Given this list of marker genes UPP1, DGUOK, GART, NUDT5, AK9, ENTPD6, GMPR2, RRM1, TXNRD1, GLRX, TYMP, UMPS, ITPA, NT5C1A, DPYD, DCTPP1, CAD, ENTPD4, TXN, UCK1, AGXT2, ENTPD1, PPAT, GUK1, NT5C2, NUDT16, RRM2, DTYMK, ADK, XDH, ADSL, NT5E, ENTPD7, ENTPD5, PUDP, UCK2, NUDT13 (nudix hydrolase 13), AK8, ENTPD3, TK2, UPP2, GSR (glutathione-disulfide reductase), TYMS, TK1 (NCBI Gene Id 7083), NUDT18, AMPD2, IMPDH1, ADA, NUDT9, ADSS1, AK5, ATIC, NME4, APRT, AMPD1, NT5M (NCBI Gene Id 56953), NT5C, GMPR, ENTPD8, PNP, ENTPD2, DCK, NME3, HPRT1, ADSS2, AMPD3, PAICS, NUDT15, DCTD, ADPRM, CTPS1, AK1, SAMHD1, DNPH1, DUT, NUDT1, PFAS, IMPDH2, CTPS2, DPYS, GMPS, AK6, MAPDA, UCKL1, NT5C3A, CMPK1, NT5C1B, NME1, AK7, CDA, DHODH, AK2, NME6, NME2, UPB1, AK4, RRM2B, GDA, here is a description of the gene set: part of: Metabolism species: Homo sapiens Reactome Pathway: Metabolism of nucleotides Nucleotides and their derivatives are used for short-term energy storage (ATP, GTP), for intra- and extra-cellular signaling (cAMP; adenosine), as enzyme cofactors (NAD, FAD), and for the synthesis of DNA and RNA. Most dietary nucleotides are consumed by gut flora; the human body's own supply of these molecules is synthesized de novo. Additional metabolic pathways allow the interconversion of nucleotides, the salvage and reutilization of nucleotides released by degradation of DNA and RNA, the catabolism of excess nucleotides, and the transport of these molecules between the cytosol and the nucleus. These pathways are regulated to control the total size of the intracellular nucleotide pool, to balance the relative amounts of individual nucleotides, and to couple the synthesis of deoxyribonucleotides to the onset of DNA replication (S phase of the cell cycle).<P>These pathways are also of major clinical interest as they are the means by which nucleotide analogues used as anti-viral and anti-tumor drugs are taken up by cells, activated, and catabolized. As well, differences in nucleotide metabolic pathways between humans and aplicomplexan parasites like Plasmodium have been exploited to design drugs to attack the latter.<p>The movement of nucleotides and purine and pyrimidine bases across lipid bilayer membranes, mediated by SLC transporters, is annotated as part of the module "transmembrane transport of small molecules".